Given this list of marker genes ENSG00000247416, ZMPSTE24, LINC00431, PISD (phosphatidylserine decarboxylase), WASHC2A, PTOV1-AS1, REXO4 (REX4 homolog, 3'-5' exonuclease), SMG1P3, TTC4, NCOA4, TRDMT1, USPL1, MEGF8, PKM, ENSG00000236846, BRWD1, STX16, SRSF10, RTEL1-TNFRSF6B, LINC01237 (NCBI Gene Id 102723927), B4GAT1, TNPO3, NR1H2, MKRN2, VPS51, ISLR2, INO80B, POLE, BORCS8 (BLOC-1 related complex subunit 8), RMND1, PCIF1, UBFD1, EFNB3, ZNF213-AS1, FAM131A, KCNIP2, TAGLN2, PLCH2, GCLC, TEFM, TLE6, RTEL1, CASZ1 (NCBI Gene Id 654487), CCDC57 (NCBI Gene Id 284001), SEMA6A, ZBTB37, ALKBH3, KBTBD4, NAT9, TSC1, INO80B-WBP1, KCTD13, SNAP47, SLC8A2, EARS2, ARHGEF12, BRD3OS, PRXL2B, ITGA7, STX18-AS1, INTS12, CCNG2, KCTD5, HMG20B, TOP3B, STMN3, YIF1B, CCNE1, CPT1C, PINK1, HSPE1-MOB4, ZER1, FBXO31, STOML1, EDC4, LMX1B, RNU7-27P, LMX1B-DT, CCDC144BP, DMAP1, SCAND3, FAM21EP, SLC24A1, NUP43, ANKRD40, BANF1, HSPE1, PUF60, ARID1A, C1orf74, JMJD4, GTPBP3, TMEM242-DT, ARHGAP1, VPS9D1, AGK-DT, MRPL4, BRPF1, AKIRIN2, CATSPERG, KCNJ4, MYLIP, EGLN2, PRRG2, CPSF1, HAX1, FAAH, CNDP2, HSPD1, MRPL44, STAT3, EXD3, NDUFS7, KCTD13-DT, ACSBG2, ARRB1, RBM28 (NCBI Gene Id 55131), SMG7, STXBP4, ZNF839, ANKRD24, XKR6, EN2, SUZ12P1, TTBK2, MED23, NLE1, SLC39A3, ZNF276, RPS7, RFXANK, GABARAP, COX11, TPI1P2, EIF2D, SVOP, B4GAT1-DT (NCBI Gene Id 102724064), TBC1D2B, LZIC, CDK4, MNT, ANAPC5, ADAM15, ZBED9-AS1, UBE2H, TMEM104, SLX9 (NCBI Gene Id 91110), LINC02593, PAFAH2, ARMT1, FCHO1, HAUS8, NR1H3, KMT2D, METTL9, AGK, SMG7-AS1, SMG8, MTMR9, GNAL, DPY19L4, MYO9B, KCNN1, INTS14, LRRC4B, TMEM242, ZNF391, CELF3, ENPP3, BRF2, GEMIN7, JPT2, LINC01775 (NCBI Gene Id 101928602), DRG2, CDK5RAP3, NMNAT1, VTRNA1-1, BLOC1S1, ATP4A, WDR11, PXMP2, UCKL1, COLGALT1, WDR11-DT, SNAP29, BORCS8-MEF2B, PI4KA, HIVEP3, ZNF408, FRA10AC1, LINC00957, ZNF581, INO80C, TRNAU1AP, ZCCHC2, MARCHF8, UBE2H-DT, SIRT6, IBA57, TCF3, NOXA1, AJUBA, ATP5MF, NCAM1, PTOV1, SNHG7, GFI1B, ZNF205, SEC13, TLR5, MBTPS2, ACP2, LINC01547, SNORA13, HMGB1, GAS5, NDUFS3, USP30, MARK4, EPB41L4A-AS1, AURKAIP1, PTCD1, PRDM8 (NCBI Gene Id 56978), LRP6, NBPF19, RASA4CP, EXOC3L4, MAP2K2, TJP3, FAM83E, AJUBA-DT, TBC1D13, UBE2Q1, ERLIN2, STX16-NPEPL1 (NCBI Gene Id 100534593), ADAP2, ENSG00000259881, STX18, GFY, NOSIP, C17orf75, MAP1LC3B, FBXW8, MRPS15, NSFL1C, ANO8, ATP5MF-PTCD1, SELENOH, MFSD12, ZMPSTE24-DT, SMARCD2, SYT7, SH2D3C, EIF1AD, SPOCD1, GSTCD, NOP16, here is a description of the gene set: Human Gene Set: KLF14_TARGET_GENES Genes containing one or more binding sites for (KLF14) in their promoter regions (TSS -1000,+100 bp) as identified by GTRD version 20.06 ChIP-seq harmonization. from publication Yevshin I, Sharipov R, Kolmykov S, Kondrakhin Y, Kolpakov F (PMID 30445619) species: Homo sapiens